Given this list of marker genes PLK2, RAP1BL, RDX, CBL, KIF14 (kinesin family member 14), RAPGEF3, RAPGEF2, RAPGEF1, RAP1B, RAP1A, RAP2A, RAP2C, CXCL13, SGSM3, RAP2B, here is a description of the gene set: studied in species Homo sapiens An intracellular signaling cassette in which a small monomeric GTPase of the Rap subfamily relays a signal. Human Gene Set: GOBP_RAP_PROTEIN_SIGNAL_TRANSDUCTION